Given this list of marker genes ANGPTL3, VEGFA, CDH5 (NCBI Gene Id 1003), EGFL7, PLXND1, ITGAV, RHOB, NR2F2, here is a description of the gene set: from publication Rankin EB, Rha J, Unger TL, Wu CH, Shutt HP, Johnson RS, Simon MC, Keith B, Haase VH (PMID 18490920) studied in species Mus musculus The von Hippel-Lindau tumor suppressor pVHL regulates the stability of hypoxia-inducible factors (HIF)-1 and -2, oxygen-sensitive basic helix-loop-helix transcription factors, which mediate the hypoxic induction of angiogenic growth factors such as vascular endothelial growth factor. Loss of pVHL function results in constitutive activation of HIF-1 and HIF-2 and is associated with the development of highly vascularized tumors in multiple organs. We have used a conditional gene-targeting approach to investigate the relative contributions of HIF-1 and HIF-2 to VHL-associated vascular tumorigenesis in a mouse model of liver hemangiomas. Here we demonstrate genetically that conditional inactivation of HIF-2alpha suppressed the development of VHL-associated liver hemangiomas and that angiogenic gene expression in hepatocytes is predominantly regulated by HIF-2 and not by HIF-1. These findings suggest that HIF-2 is the dominant HIF in the pathogenesis of VHL-associated vascular tumors and that pharmacologic targeting of HIF-2 may be an effective strategy for their treatment. Human Gene Set: RANKIN_ANGIOGENIC_TARGETS_OF_VHL_HIF2A_DN Angiogenic genes down-regulated in hepatocytes after knockout of VHL and HIF2A.